The following is a description of a gene set: Human Gene Set: GOMF_MONOATOMIC_ANION_SODIUM_SYMPORTER_ACTIVITY Enables the transfer of a solute or solutes from one side of a membrane to the other according to the reaction: monoatomic anion(out) + Na+(out) = monoatomic anion(in) + Na+(in). species: Homo sapiens, and this is the list of marker genes: SLC5A5, SLC6A6, SLC12A3, SLC6A11, SLC18A2 (NCBI Gene Id 6571), SLC13A1 (NCBI Gene Id 6561), SLC12A2, SLC6A12, SLC6A8, SLC6A1, SLC6A2, SLC6A4 (solute carrier family 6 member 4), SLC12A1, SLC6A3, SLC18A1, SLC6A18, SLC6A13, SLC22A1